Given this list of marker genes LHX2 (NCBI Gene Id 9355), PAX2, NSD2, SPTBN4, GPX1, THRB, here is a description of the gene set: species: Homo sapiens Human Gene Set: CGGTGTG_MIR220 Genes having at least one occurence of the motif CGGTGTG in their 3' untranslated region. The motif represents putative target (that is, seed match) of human mature miRNA hsa-miR-220 (v7.1 miRBase).